Given this list of marker genes Cenpi, Exosc5, Nr5a1 (NCBI Gene Id 26423), Sac3d1, Yaf2, Ddn, Nudcd3, Ube2n, Cct2, Tex19.1, Rcc1, Castor1, Spry2, Retsat, Crb2, Nup37, Mettl16, Prps1 (NCBI Gene Id 97786), Pex5, Klhdc2, Phox2a, Rars1, Pcmt1, Slc25a3, Spdl1, Nop16, Ipo5, Pacc1, Nsl1, Rnmt, Trim71, Kifap3, Lrp2, Prelid3a, Trpc5os, Grwd1 (glutamate-rich WD repeat containing 1), AI837181, Ngef, Tcam1, Hes7, Tex11, Aldh9a1 (NCBI Gene Id 56752), Rrp15, Smtn, Nptx1, Tigd5, Etaa1, Hgh1, Pax6, Thoc3 (NCBI Gene Id 73666), Tsfm, Spout1, Snrpb, Adamts8, Sco2, Ptcd3, Slc9b1, Sf3b4, Tcof1, Znhit2, Ankrd6, Qsox2, Hcn2, Racgap1, L2hgdh, Gdap1l1, Svop, Tsr1, Gipc3, Npm3, Pax9, Zfp334, Gcsh, Rrp12, Enkd1, Spag6, Hnrnpa1, Prr19, Lmnb2, Timm8a1, Tuba1c, Klhl21, Ola1, Morc1, Nop2, Cct5, Pom121, Fkbp11, Ube2i, Pim3, Best3, Brsk2, Nup107, Ddx21, Fbxo41, Tomm40, Echdc3, Slc35g2, Gxylt1, Eif2s1, C1qbp, Srp9, Vgf, Trmt61a, Megf8, Tipin, Lrpprc, Rps3a1, Bcl2l1, Nolc1, Kiss1r, Diras1, F8a (NCBI Gene Id 27589), Cda (NCBI Gene Id 72269), Rnf187, Bora, Tfap4, Mdm2, Snrpf, Esx1, Ube2j2, Sec1, Drap1, Trim27, Tars3, Rrs1, Eef1d, Naf1, Kdm8, Ndc80, Nomo1, Zbtb44, Shmt2, Utp11, Chrm4, Mybbp1a, Celf5, Trnau1ap, Tmem145, Spry4, Pak1ip1, Ahcy, Itga6, Lsm11, Cdr2l, Trp53, Dpp9, Kcnn4, Mphosph10, Polr1a, Wdr55, Eef2, Nemp1, Rab21, Cers5, Ccnf, Nap1l1 (NCBI Gene Id 53605), Rbm45, Asphd1 (NCBI Gene Id 233879), Klf16, Rtcb, Taf4b, Zfp979, Pcnx4, Vbp1, Pigm, Dlx2, Hcn3, Gtpbp4, Flvcr1, Erh, Nup42, Pa2g4, Pycr2, Tacr2, Raet1d, Lclat1, Slc24a1, Dkc1, Rax, Nol9 (nucleolar protein 9), Bcap31, Slc19a1, Ercc6l, Hars1, Thap4, Pwp1, Srm, Hibadh, Disp2, Tcea1, Pwp2, Ilrun, Dagla, Rex2, Gid4, Hspd1, Eif3i (eukaryotic translation initiation factor 3, subunit I), Park7, Ash2l, here is a description of the gene set: Most patients with cancer are refractory to immune checkpoint blockade (ICB) therapy, and proper patient stratification remains an open question. Primary patient data suffer from high heterogeneity, low accessibility, and lack of proper controls. In contrast, syngeneic mouse tumor models enable controlled experiments with ICB treatments. Using transcriptomic and experimental variables from >700 ICB-treated/control syngeneic mouse tumors, developed a machine learning framework to model tumor immunity and identify factors influencing ICB response. Projected on human immunotherapy trial data, found that the model can predict clinical ICB response. further applied the model to predicting ICB-responsive/resistant cancer types in The Cancer Genome Atlas, which agreed well with existing clinical reports. from publication Zeng Z, Gu SS, Wong CJ, Yang L, Ouardaoui N, Li D, Zhang W, Brown M, Liu XS (PMID 36240281) Metagene derived from the control samples, found to be predictive of immune checkpoint blockade treatment resistance, not otherwise discussed. Mouse Gene Set: ZENG_GU_ICB_CONTROL_METAGENE_21_PRECICTIVE_ICB_RESISTANCE species: Mus musculus